Given this list of marker genes Rap1gap, Il2rg, Pros1, Apoa2, Fcer1g, Rab27a, Gas6, Colec10, Hspa8, Ccr7, Btk, Myh9, Fpr-rs3, Clec7a (C-type lectin domain family 7, member a), Fcgr3, Fpr-rs7, Mertk, Ighg1, Pparg, Il15ra, Lyar, Fcgr1, Mex3b, F2rl1, Rab31 (RAB31, member RAS oncogene family), Myo18a, C3, Ano6, Ptprj, Ighg2b, Pycard, Dnm2, Nod2 (NCBI Gene Id 338538), Fcnb, Nckap1l, Cfp, Tub (NCBI Gene Id 22141), Appl2, Tulp1 (TUB like protein 1), Ptk2, Ptprc, Lrp1, Sftpd, Calr, Ifng, Fpr-rs6, Il2rb, Plcg2, Il15, Lman2 (NCBI Gene Id 68561), Sirpa, Itga2, Cd47, Lbp, Ahsg, Cd36 (CD36 molecule), C2, Abca7, Sirpb1a, Apoa1, Arap1, Mbl2, Cd209b, Cd300lf, Sod1, Fcgr2b, Ptx3, Sftpa1, Cyba, Bcr, Ager, Ccl2, Fpr2, Fpr-rs4, Abr, Mbl1, Colec11, Pla2g5, Stap1, Camk1d, Trem2, Rap1a, Slc11a1, Gata2, Rapgef1, Dock2, here is a description of the gene set: species: Mus musculus Mouse Gene Set: GOBP_POSITIVE_REGULATION_OF_PHAGOCYTOSIS Any process that activates or increases the frequency, rate or extent of phagocytosis.